Given this list of marker genes Prdm1, Mdfi, Hand1, Akt1, Fzd5, Grhl2, Itgav, Plk4, Krt19, Cts8 (NCBI Gene Id 56094), Snai1, Cts7 (NCBI Gene Id 56092), Nr2f2, Hectd1, Dnajb6, Sox15 (NCBI Gene Id 20670), Gcm1, Erf, Elf5, Stk4, Spint2, E2f7, Eomes, Krt8, St14, Ascl2, Xist, Gjb5, Plg (plasminogen), E2f8, Senp2, Lif, Stk3, here is a description of the gene set: Mouse Gene Set: GOBP_CELL_DIFFERENTIATION_INVOLVED_IN_EMBRYONIC_PLACENTA_DEVELOPMENT studied in species Mus musculus The process in which a relatively unspecialized cell acquires specialized features of the embryonic placenta.